Given this list of marker genes Col19a1, Rps7, Rab30, Gspt1, Ulk1, Kif21b, Rtn4rl1, Rab3c, Ifitm2, Niban1, Hif1an, Nek6, Grpel2, Basp1, Tceal7, Fgf18, Sertad4, Man2b1, Igsf10, Sike1, Clrn1, Mdga1, Wdr31, Prrt3, Unc13b, Hspbp1, Crebzf, Prkcsh, Katnbl1, Gucy2e, Sash1, Dnal1, Sox7, Tmem135, Lin7c, Nono, Kremen1, Il31, Nsl1, Nyap2, Scamp4, Canx, Selplg, Nudt4 (nudix hydrolase 4), Gosr2, Crim1, Rab7, Zfp791, Rab2a, Sult1c2, Extl2, Polr1a (polymerase (RNA) I polypeptide A), Olfml3, Prdm4, Cfap119, Mlx, Fdft1, here is a description of the gene set: species: Mus musculus Mouse Gene Set: MIR_3093_3P Genes predicted to be targets of miRBase v22 microRNA mmu_miR_3093_3p in miRDB v6.0 with MirTarget v4 prediction scores > 80 (high confidence targets). from publication Chen Y, Wang X (PMID 31504780)